The following is a description of a gene set: Mouse Gene Set: GOBP_INDOLE_CONTAINING_COMPOUND_BIOSYNTHETIC_PROCESS The chemical reactions and pathways resulting in the formation of compounds that contain an indole (2,3-benzopyrrole) skeleton. species: Mus musculus, and this is the list of marker genes: Aanat, Gch1, Fev, Aldh2, Cyp2d22, Tph1, Ddc, Tph2, Asmt